Given this list of marker genes Ift88, Tubb2b, Tuba1b, Tuba3b, Dynll1, Dync1li2, Ubb, Prkn, Tuba4a, Park7, Rps27a, Cetn1, Tubal3, Tubb6, Ube2n, Vim (vimentin), Tuba1c, Tuba1a, Tuba8, Tubb4a, Ube2v1, Tubb4b, here is a description of the gene set: This event has been computationally inferred from an event that has been demonstrated in another species.<p>The inference is based on the homology mapping from PANTHER. Briefly, reactions for which all involved PhysicalEntities (in input, output and catalyst) have a mapped orthologue/paralogue (for complexes at least 75% of components must have a mapping) are inferred to the other species. Reactome Pathway: Aggrephagy species: Mus musculus part of: Selective autophagy electronically inferred by orthology from the curated human pathway